The following is a description of a gene set: Mouse Gene Set: chr7A3 species: Mus musculus, and this is the list of marker genes: Gm38973, Gm5890, Api5-ps, Gm18463 (predicted gene, 18463), Nkpd1, Vmn1r-ps74, Gm26802, Vmn1r157 (NCBI Gene Id 667551), Gm18195, Zfp780b, Mypopos, Gm4207, Vmn1r143, Gm8600, Vmn1r243, Gemin7, Mill1, Foxa3, Vmn1r118, Itpkc, Gm4567, Gm18466, Vmn1r159, Rab4b, Vmn1r251, Vmn1r166, Rps16, Gm10670, Igsf23, Zfp61, Dll3, Vmn1r246 (vomeronasal 1 receptor 246), Cnfn, Gm10046, Zfp607b, Bloc1s3, Gm18061, Cyp2a5, Polr1g, Apoc1, Exosc5, Gm18455, Fbxo46, Apoe, Cxcl17, Gm16451, Gipr, Prr19, Gm4528, Gm18057, Lypd5, Vmn1r135, Cyp2b26-ps, Gm8728, Gm18055, Psg23, Eml2, Vmn1r129, Mir7048, Prkcz2, Vmn1r124, Gm6176, Clasrp, Pafah1b3, Mir1191, Vmn1r121, Meiosin, A930016O22Rik (NCBI Gene Id 654797), Gm8902, Cyp2b10, Mark4, Gm17780, Sertad1, Gsk3a, Gm6434, Gm5891, Zfp974, Zfp180, Gm30146, Sympk, Akt2 (thymoma viral proto-oncogene 2), Vmn1r-ps84, Zfp59, Timm50, Ercc2, Gm10668, Gm4574, Snrpd2, Psg19, AF357399, Gm38569, Ttc9b, Vmn1r-ps73, Vmn1r255, Irgc, Vmn1r167 (vomeronasal 1 receptor 167), Ceacam2, Atp1a3, Vmn1r-ps79, Coq8b, Vmn1r170, Vmn1r-ps83, Erf, Blvrb, Nlrp4e, Gm15570, Gm10665, Vmn1r184, Vmn1r-ps80, Vmn1r142, Ptma-ps1, Eid2b, Gm16456, Ppp1r13l, Ckm, Vmn1r-ps70, Psg20, Gm18469, Vmn1r123, Bckdha, Gm5893, Gm19092, Phldb3, Vmn1r254, Irgq, Vmn1r181, Gm4548, Fosb (FBJ osteosarcoma oncogene B), Zfp575, Gm5587, Vasp, Cyp2a4, Gm15495, Vmn1r185, Gm26891, Psg25, Cyp2b13, Cyp2f2, Vmn1r100, Vmn1r177, Ceacam16, Gm26550, Gm10175, Ethe1, Zfp93, Rpl7a-ps8, Gm8708, Tescl (tescalcin-like), Apoc4, Rsph6a, Gm18056, Prx, Gm18060, Ceacam10, Cyp2b27-ps, Vmn1r103, Vmn1r245, Vmn1r244, Vmn1r115, Vmn1r93, Gm36694 (NCBI Gene Id 102640682), Zfp235, Mir3100, Dmrtc2, Gm18207, Rps19, Gm4541, Gm29920, Vmn1r116, Sertad3 (NCBI Gene Id 98671), Vmn1r179, Cd79a, Map3k10, Gm18877, Zfp607a, Nlrp9b, Vmn1r247, Vmn1r114, Ceacam19, Numbl, Gm50477, Mir343, Dmpk, Gm15567, Rabac1, Tmem91, Vmn1r101, Vmn1r111, Gm19091, Ceacam20 (CEA cell adhesion molecule 20), Gm16443, Vmn1r183, Vmn1r260, Gm25790, Megf8, Zfp109, Josd1-ps, Pvr, Gm8314, Gm18126, Cyp2a21-ps, Gm18458, Lypd3, Zfp626, Rnf170-ps, Mir7047, Gm18468, Zfp574, Cyp2b23, Vmn1r258, Cyp2s1, Gm8745, Gm4607 (predicted gene 4607), Ccdc97, Vmn1r127, Six5, Vmn1r248, Gm18672, B9d2, Fcgbp, Gm45011, Gm16251, Gm10662, Relb, 9130221H12Rik, Vmn1r-ps86 (NCBI Gene Id 100312515), Eid2, Bcl3, Vmn1r257, Cyp2g1, Ercc1, Vmn1r175, Cd177, Gm18462, Gm15541, Gm18049, Gm18470, Pld3, Gm18054, Kcnn4, Pinlyp, Qpctl, Gm44513, Ceacam1, Cic, Zfp296, Dmwd, Pgam1-ps2, Gm4565, Zfp112, Ppp1r37, Clptm1, Vmn1r176, Opa3, Gm5157, Gm20949, Zfp108, Gm4536, Mypop, Gm23099, 4732471J01Rik, 2200007N16Rik, Mir7046, Psg22, Gm18058, Gm26707, Egln2, Ltbp4, Nova2, Gm19900, Shkbp1, Gm42375, Gm18467, Vmn1r-ps71, Gm4526, Zfp850, Vmn1r158, Mill2, Vmn1r148, 1700058P15Rik, Vmn1r139, Ccdc61, Ppm1n, Vmn1r-ps85, Cadm4, Vmn1r152, Gm18063, Gm36776, Vmn1r151, Gm5324, Psmc4, Psg17, Nlrp9a, Vmn1r138, Pglyrp1, Vmn1r173, Gm18306, Gm18465, Sycp1-ps1, Plaur, Plekhg2, Gm19126, Apoc2, Gm4598, Gm25134, Vmn1r104, Zfp428 (NCBI Gene Id 69213), Tgfb1, Irf2bp1, Vmn1r171, Gm4880, Gm8685, B3gnt8, Vmn1r253, Lipe, Vmn1r180, V1rd19, Lypd4, Cyp2a12, Tomm40, Gm4290 (NCBI Gene Id 100043199), Vmn1r169, Klc3, Psg27, Vmn1r241, Vmn1r137, Vmn1r259, Gm36159, Vmn1r168, Cblc, Vmn1r250, Vmn1r172, Tmem145, Gm50092, Gm6882, Vmn1r249, Gm45034, Vmn1r-ps75, Vmn1r149, Gpr4, Axl, Vmn1r112, Psg28, Vmn1r132, Gm31024, Nlrp4a, Zfp526, Fcgbpl1, Vmn1r122, Sptbn4, Gm4557, Zfp60, 4933430L12Rik, Gm18464 (predicted gene, 18464), Nlrp9c, Tmsb10b, Vmn1r95, Gm18206, Gm18461, Bcam, Gm4501, Mir6537, Gm4545, Cyp2b9, Vmn1r-ps76 (vomeronasal 1 receptor, pseudogene 76), Smg9, Gm29918, Mia, D930028M14Rik, Vmn1r178, Psg21 (pregnancy-specific beta-1-glycoprotein 21), Gm10676, Gm16184, Vmn1r165, Gm18059 (predicted gene, 18059), Dmac2, Vmn1r94, Gm29763, Mir3101, Rtn2, Dyrk1b, Exoc3l2, Nlrp5, Zfp94, Apoc2l, Xrcc1, Vmn1r130, Gm6902, Gm33626, Fbl (NCBI Gene Id 14113), BC026762, Erfl, Gm18062, Dedd2, Arhgef1, Gm24356, Gm4558, Vmn1r117, Hipk4, Gm18598, Lypd10, Vmn1r113 (vomeronasal 1 receptor 113), Vmn1r-ps77, Nectin2, Actmap, Cyp2a22, Vmn1r163, Vmn1r91, Zfp114, Vmn1r155, Krt8-ps, Vmn1r125, 2310022A10Rik, Pou2f2, Vmn1r107, Vmn1r126, Vmn1r174, Gm18052, Gm17982, Vmn1r242, Vmn1r252, Mir330, Psg26, Cyp2b19, Gm18855, Lypd11, Snrpa, Supt5 (NCBI Gene Id 20924), Gm4613, Vmn1r131, Gm19345, Gm4513, Vmn1r256 (vomeronasal 1 receptor 256), Gm18460, Vmn1r119, Grik5, Erich4, D830036C21Rik, Psg18, Selenov, Tex101, Gm18471 (NCBI Gene Id 100417232), Gm5997, Vmn1r160, Hnrnpul1, Nanos2, Vmn1r240, Cyp2t4, Vmn1r-ps78, Gm8486, Trappc6a, Gm29754, Vmn1r128, Vmn1r120, Gm15883, Zfp111